Given this list of marker genes vpr, BANF1, vif, HMGA1, vpu, gag, rev, gag-pol, PSIP1, here is a description of the gene set: Following nuclear entry, the viral preintegration complex (PIC) must select a site for integration in a host cell chromosome, and then carry out the chemical steps of the reaction. <p>At the chromosomal level, HIV has been found to favor active transcription units for integration. Subsequent studies established that the cellular PSIP1/LEDGF/p75 protein is important in this reaction. PSIP1/LEDGF/p75 binds tightly to HIV integrase, and also to chromatin. Knocking down PSIP1/LEDGF/p75 in cells resulted in several perturbations of integration targeting in vivo, including reduced integration in transcription units. Thus PSIP1/LEDGF/p75 has been hypothesized to act as a tethering factor that dictates at least in part the placement of HIV integration sites. <p>The integration target DNA is also expected to be coated with nucleosomes. Tests of integration into mononucleosomes in vitro have shown that wrapping integration target DNA actually boosts integration activity. Kinked positions on the DNA gyre are particularly favored for integration. <p>Integration does not take place at a unique sequence in the integration target DNA (i.e. it is not like a restriction enzyme). However, favored and disfavored primary sequences can be detected when many integration sites are aligned. Synthesis and testing of favored HIV integration sites showed that they were favored for integration by PICs in vitro. <p>After a target DNA is bound, the integration reactions take place via a single-step transesterification.<p>Integration of both ends of the viral DNA, followed by melting of the target DNA segments between the points of joining, yields single stranded gaps at each host-virus DNA junction, and a two base overhang derived from the viral DNA. The manner by which this intermediate is subsequently repaired to yield the fully integrated provirus is unclear. For many parasitic DNA replication reactions, the parasite carries out reaction steps only up to a point that the host cannot easily reverse, forcing the host to complete the job. For retroviral integration, it is reasonable to infer that host DNA repair enzymes complete provirus formation. DNA gap repair enzymes are known to be involved in a variety of DNA repair pathways, so their recruitment to gaps at host-virus DNA junctions is readily envisioned. Consistent with this, known gap repair enzymes have been shown to act on model host-virus DNA junctions in vitro. Reactome Pathway: Integration of viral DNA into host genomic DNA part of: Integration of provirus studied in species Homo sapiens